Given this list of marker genes CCR2, CLU, PLA2G5, CR1, FCGR2B, here is a description of the gene set: species: Homo sapiens Human Gene Set: GOBP_IMMUNE_COMPLEX_CLEARANCE A process directed at removing immune complexes from the body. Immune complexes are clusters of antibodies bound to antigen, to which complement may also be fixed, and which may precipitate or remain in solution.